The following is a description of a gene set: Reactome Pathway: Gastrulation electronically inferred by orthology from the curated human pathway This event has been computationally inferred from an event that has been demonstrated in another species.<p>The inference is based on the homology mapping from PANTHER. Briefly, reactions for which all involved PhysicalEntities (in input, output and catalyst) have a mapped orthologue/paralogue (for complexes at least 75% of components must have a mapping) are inferred to the other species. studied in species Mus musculus part of: Developmental Biology, and this is the list of marker genes: Tfap2a